Given this list of marker genes FGF3, MYO15A, CIB2, KCNE1, KARS1, KCNQ1, NEUROG1 (neurogenin 1), SLC12A2, PRPS1, PMP22, RDX, here is a description of the gene set: Profound sensorineural hearing impairment Human Gene Set: HP_PROFOUND_SENSORINEURAL_HEARING_IMPAIRMENT Complete loss of hearing related to a sensorineural defect. species: Homo sapiens